Given this list of marker genes Acsm2, Acsm5, Glyatl3, Glyat, Acsm1, Acsm4, here is a description of the gene set: Mouse Gene Set: REACTOME_AMINO_ACID_CONJUGATION Amino Acid conjugation studied in species Mus musculus